The following is a description of a gene set: part of: Signaling by GPCR studied in species Mus musculus Reactome Pathway: GPCR downstream signalling electronically inferred by orthology from the curated human pathway This event has been computationally inferred from an event that has been demonstrated in another species.<p>The inference is based on the homology mapping from PANTHER. Briefly, reactions for which all involved PhysicalEntities (in input, output and catalyst) have a mapped orthologue/paralogue (for complexes at least 75% of components must have a mapping) are inferred to the other species., and this is the list of marker genes: P2ry1, Hcar2, Lpar2, Casr, Fpr-rs4, Ccl21a, Ntsr1, Drd3, Cnr2, Ntsr2, Avpr1b, Hcrtr1, Sos2, Tas2r120, Tas1r2, Ccr4, Gpr143, Qrfprl, Cdc42, Tas2r136, Gpr176, Taar9, Gipr, C3, Sstr4, Pde2a, Cxcr6, Gabbr1, Arhgef7, Grk3, Gnaz, Ngef, Gpr83, Oprl1 (NCBI Gene Id 18389), Mchr1, Ccl20, Ghrh, Gprc6a, Ccl11, Cxcl12, Rgs8, Gcg, Oprd1, Nmur2, Fgd2, Sct, Pyy, Gnrhr, P2ry13, Pcp2, Bdkrb2 (bradykinin receptor, beta 2), Mapk7, Tas2r144, Rgs7 (regulator of G protein signaling 7), Tas2r119, Galr2, Pik3r5, Uts2, Arhgef37, Pth2r, Rgs2, Sstr1, Cckbr (NCBI Gene Id 12426), Gng11, Arhgef33, Daglb, Adcy5, Ccr8, Ptgdr2, Nms, Mc4r, Oxtr, Hebp1, Aplnr, Gpr20, Pth2 (NCBI Gene Id 114640), Chrm1, Cnr1, Taar8c, Pnoc, Drd4, Gnb5, Fshr, Ccr6, Kng2, Hras, Vav1, Rln3, Ccl9, Ccr3, Gnb3, Opn1sw, Oxgr1, Adra1a, Tacr1, Fshb, Ccl21f, Gng8, Avpr2, Cxcr3, Psap, Gpsm2, Cxcl16, P2ry10, Prokr2, Insl5, Htr1f, Gnat3, Ppp1ca, Edn3, Gcgr, Mmp3, Adm2, Ghrhr, Dgkh, Gnat1, Ccl28, Npw, Sstr3, Adra2b, Gng3, Rxfp2, Trpc7, Htr2c, Tas2r105, Avp, Gip (NCBI Gene Id 14607), Fpr-rs6, Pde10a, Itga5, Pdpk1, Hrh2, Cdk5, Ccr1, Hcrtr2, F2, Agtr2, Arhgef17, Trh, Prkacb, Adrb3, Gpr15, Taar8b, Pomc, Cxcl10 (C-X-C motif chemokine ligand 10), Adcy8, Gper1, Oxt, Tas2r107 (NCBI Gene Id 387342), Tas2r131, Rhob, Gpbar1, C3ar1, Nmu, Trpc6, Gpsm3, Sctr, Prkar1b, Glp2r, Hrh1, Fpr1, Ccl4, Nmb, Prok1, Prok2, Adrb1, Gngt2, Arrb2, Gpr65, Rgr, Pik3r2, Gnb2, Gna14, Arhgef39, Trhr, Brs3, Htr7, Ccl6, Cxcr2, Cxcl1, Cysltr1, Hcrt, Gng4, Grk6, Ccl5 (NCBI Gene Id 20304), Pth1r, Prkaca, Galr1, Lpar4, Oprm1, Gpr132, Ccl19, Ccl21e, Camkk1, Taar1, Adcy7, Tacr2 (NCBI Gene Id 21337), S1pr5, Gpr84, Ppp2r1b, Tshr, P2ry2, Prkcg, Opn4, Rho, Chrm4, Taar5, Ccr7, Npy2r, Gna13, Cxcr5, Adm, Arhgef10l, Grp, Pde8a, Adora2a, F2rl1, Ptger1, Cysltr2, Gnai1, Gna12, Gpr4, Sstr2, Tas2r121, Lpar5, Vip, Rgs6, Kiss1r, Grm4, Gpr68, Egfr, Sucnr1, Cxcl3, Galr3, Arhgef3, Glp1r, Avpr1a, Crhr2 (corticotropin releasing hormone receptor 2), Rgs14, Fgd1 (NCBI Gene Id 14163), Gpr17, Xcr1, Mc1r, Opn5, Cga, Tas2r130, Npb, Gng5, Ltb4r1, Pde1c, Cxcr1, Drd5, Uts2b, Cckar, Opn3, P2ry4, Arhgef15, Sst, Camkk2, Itsn1, Grb2, Rgs4, Htr1b, Shc1, Hcar1, Mc3r, Plcb3 (NCBI Gene Id 18797), Tas1r3, Mc2r, Prkch, Fpr-rs7, Nts, Gngt1, Ramp3, Cxcl9, Ptger4, Dgki, Gal (NCBI Gene Id 14419), Grk5, Mapk3, Edn2, Tbxa2r, Arhgef12, Nmur1, Gpr150, Tas2r135, Tac2, Rgs18, F2rl3, Chrm3, Cxcl2, Npy1r, Arhgef1, Edn1 (endothelin 1), Ffar1, Pde7b, Ptgdr, S1pr4, Tas2r118, Hc, Cx3cr1, Dgka (NCBI Gene Id 13139), Tas2r137, Ccr10, Arhgef38, Ppy, Adcyap1, Grpr, Adra2c, Cck, Prkar2b, Rxfp4, Ghsr, Tas2r139, Qrfp, Bdkrb1, Mc5r, Rgs1, Prex1, Ffar3, Lpar3, Tas2r126, Dagla, Fpr-rs3, Npy4r, Ffar2, Mtnr1a, Iapp, Hrh4, Rgs9, Cort, Cxcr4, Dgkb, Arhgef10, Gpha2, Gphb5, Tas2r108, Ptgir, C5ar1, Crhr1 (corticotropin releasing hormone receptor 1), Vipr1, Rrh, Rxfp3, Htr4, Pf4, Vipr2, Htr5a, Gpr27, Tas2r138, Lpar6, Ednrb, Ppp2r5d, Gast, S1pr3, Gpr183 (G protein-coupled receptor 183), Adra2a, Kiss1, Pde1b, Gng7, Npffr1, Prkca, Calm1, Npsr1, Ptger2, Chrm2, Uts2r, Gng10, Taar3, Prokr1, Htr6, Penk, Rgs16, Npff, Rgs13